The following is a description of a gene set: Lenticonus Human Gene Set: HP_LENTICONUS A conical projection of the anterior or posterior surface of the lens, occurring as a developmental anomaly. studied in species Homo sapiens, and this is the list of marker genes: CRYAB, COL4A4, PRPH2, COL4A5, COL4A3, RLBP1, LAMB2, RDH5, RHO, COL4A6